The following is a description of a gene set: Genes predicted to be targets of miRBase v22 microRNA hsa-miR-3913-5p in miRDB v6.0 with MirTarget v4 prediction scores > 80 (high confidence targets). Human Gene Set: MIR3913_5P from publication Chen Y, Wang X (PMID 31504780) species: Homo sapiens, and this is the list of marker genes: SMAD2, SIGLEC10, MRTO4, CEP20, IQCK, PER1, GPR158, GNL3L, BCO2, EIF4EBP2 (eukaryotic translation initiation factor 4E binding protein 2), SKP1, TMPRSS11A, CSGALNACT2, GPC6, ACMSD, TSPAN6, MEX3C, PRDM16, KIAA0408, FCGR2A, ZNF704, ALDH5A1, CAVIN3, ZNF236, C2orf88 (chromosome 2 open reading frame 88), STK17A, NEXMIF, SLITRK6, MAN1A1, TRPS1, ZIC1, MTCL2, YWHAZ, ERGIC1, GCSAM (germinal center associated signaling and motility), GORASP1, GOT1, C11orf58, ANKRD17, NDC1, PIP4K2A, GZF1, RUSC1, ESR1, PPM1F, CORO1C, CTBP2, IDI2, GPBP1L1, RHAG, PLEKHS1, CBX2, TMEFF2 (NCBI Gene Id 51753), BLNK, EFNA5, MYO1A, SAMD9, CDH12, ETNK1 (ethanolamine kinase 1), COX15, GPATCH4, NRF1, VSNL1, GATD3, CLIP3, OST4, CMPK2, NMBR, SERINC5, TNRC6A, DDX31, SHPRH, MYF5, HOOK3, CDK19, PSMC4, AP1G2, SULT1C2, KRT222, DCLK3, ITGAE, SEPTIN3, APOBEC3F, RHPN2, PDK3, USP48, YWHAQ (tyrosine 3-monooxygenase/tryptophan 5-monooxygenase activation protein theta), LIAS